The following is a description of a gene set: Reactome Pathway: Activated NTRK3 signals through PLCG1 The receptor tyrosine kinase NTRK3 (TRKC), when activated by its ligand NTF3 (NT-3), induces PLCG1 phosphorylation, triggering PLCG1 signaling. studied in species Homo sapiens part of: Signaling by NTRK3 (TRKC), and this is the list of marker genes: PLCG1, NTRK3, NTF3